The following is a description of a gene set: studied in species Homo sapiens from publication Schaefer CF, Anthony K, Krupa S, Buchoff J, Day M, Hannay T, Buetow KH (PMID 18832364) Internalization of ErbB1 Human Gene Set: PID_ERBB1_INTERNALIZATION_PATHWAY, and this is the list of marker genes: UBE2D2, CBL, KRAS, EPN1, GRB2, HRAS, EGFR, UBE2D3, SPRY2, ITSN1, HGS, RAB5A, UBE2D1, SOS1, PIK3CD, SH3KBP1, CHMP3, PIK3CA (phosphatidylinositol-4,5-bisphosphate 3-kinase catalytic subunit alpha), SH3GL2, LRIG1, PIK3R3, PIK3R2, DNM1, EPS15, ZFYVE28, AMPH, SRC, ARHGEF7, SYNJ1, TSG101, USP8, PIK3R1, CDC42, SHC1, STAMBP, EGF, PIK3CB, PTK2, CBLB, RAF1, NRAS